Given this list of marker genes PIGY, ODC1, SF3B4, ZFX, DHODH, CTCF, SMS, ZNF292, TWIST1, MED12, GNAI3, PGAP2, ZNF462, ERI1, HUWE1, PQBP1, KMT2D, POU3F3, AFF4, EYA1, CHD4, TCF4, PIGN, IPO8, PGAP3, KDM6A (NCBI Gene Id 7403), FIG4, UBAP2L, PRR12, ASXL2, PIGV, PIEZO1, RNU4-2, PLXNA1, FGFR2, CHD7, FGF10, SCNM1, BCOR (BCL6 corepressor), FRAS1, DACT1, WLS, DDX11, ZEB2, SUPT16H, BRWD3, BCL11A, PIGW, QRICH1, EDNRA, AHDC1, IGBP1, CSNK2A1, RIPK4, FOXL2 (NCBI Gene Id 668), PAX1 (NCBI Gene Id 5075), ECE1, PIGL, MBD5, KCTD1, ZMYM3, ADNP, DNAJC21, DHCR24, EIF5A, TBX2, SPTBN1, PIGO, FGFR3, FBXW11, SIN3A, SIX1, CHD5, here is a description of the gene set: studied in species Homo sapiens Laterally protruding ear that lacks antihelical folding (including absence of inferior and superior crura). Human Gene Set: HP_CUPPED_EAR Cupped ear